The following is a description of a gene set: A prolongation or process extending from a glial cell. species: Mus musculus Mouse Gene Set: GOCC_GLIAL_CELL_PROJECTION, and this is the list of marker genes: Crb1, Cfap53, Tmem50a, Akr1b1, Pacrg, Sirt2, Ermn, Crocc, Syt4, Akap9, Dmd, Dnah9, Lcp1, Kcnj10, Pink1, Dnai2, Fmr1, Mt3, Dnai1, Slc17a8, Grm3, Abca7, Ezr, Ccdc39, Slc2a13, Eif2s1, Adcy10, Adgrg1, App, Slc1a1, Kcnk2, Dnah5, Aif1, Wasf3, Slc7a11, Grm5, Grm2, Nfasc, Slc4a8, Gfap, Gas8, Gjb2, Cnga3, Itgb1, Dnali1, Gpr161, Mlc1, Atp1b2, Hepacam, Cep164, Fyn, Cntf, Aqp4, Cetn2, Clcn2 (chloride channel, voltage-sensitive 2), Mapt, Slc1a2, Cfap221, Glul, Scn7a, Lgals3